Given this list of marker genes Clcn2, Kcnj10, Ezr, Grm3, Adgrg1, Mlc1, Slc17a8, Mt3, Atp1b2, Adcy10, Slc2a13, Dmd, App, Eif2s1, Slc7a11, Grm2, Kcnk2, Aqp4, Hepacam, Pink1, Slc1a2, Gjb2, Syt4, Grm5, Gfap, here is a description of the gene set: A prolongation or process extending from the soma of an astrocyte and wrapping around neurons. Mouse Gene Set: GOCC_ASTROCYTE_PROJECTION studied in species Mus musculus